The following is a description of a gene set: Transcriptome of human HepaRG hepatocellular carcinoma liver progenitors in responses to a WNT3A-enriched microenvironment and dissection of pathways dependent on _-catenin and/or blocked by the SFRP-like Wnt inhibitor FZD8_CRD. from publication Mebarki S, Désert R, Sulpice L, Sicard M, Desille M, Canal F, Dubois-Pot Schneider H, Bergeat D, Turlin B, Bellaud P, Lavergne E, Le Guével R, Corlu A, Perret C, Coulouarn C, Clément B, Musso O (PMID 27191501) species: Homo sapiens Methods: Liver progenitor cells were incubated in a WNT-enriched microenvironment for 72hrs (200 ng/ml mouse recombinant purified Wnt3A from R&D Systems). Gene pathways dependent on downstream _-catenin were studied by _-catenin knockdown with specific siRNA. Gene pathways blocked by extracellular SFRP-like Wnt inhibitors were studied by co-incubating cells with recombinant purified FZD8_CRD (300 ng/ml, from R&D Systems). Independent culture experiments performed in triplicate include untreated cells or cells incubated with scrambled siRNA or with _-catenin-specific siRNA or with FZD8_CRD, alone or in combination with Wnt3A. Human Gene Set: MEBARKI_HCC_PROGENITOR_WNT_UP, and this is the list of marker genes: ENO2, ARHGDIB, PTPN22, MRC2, LCP1, CCN1, LCE1A, BMF, PRICKLE2, ALDH3A1, BNC2, FLNA (filamin A), ST6GAL2, CDCP1, CARMN, PKP3, PANX2, LRRC15, NDRG4, WFDC3, CENPVL3, TCF7, RASSF9, SEPTIN11, TNFAIP6, SPARC, CLIC3, LYPD1, EXT1, RDH10, HMCN1, LINC01173, DIP2C-AS1, IL1R1, CXCL3, TEX15, NINJ2, NR2F1-AS1, NIFK-AS1, ENSG00000227496, GRAMD1A, ITGB4, ENDOD1, ADAM19, TCHH, SLC26A2, FHL2, NXN, FIBCD1, TYRP1, CCDST, LZTS1, FBN1, CORO1C, CLDN2, SRPX2, CYP1B1, THBS2, TCOF1, ZNF827, SLC7A5, STK32B, PRAG1, MMP2, LINC03033, KANK1, COL5A2, JAM2, NANOS1, PCSK5, CCDC3, GBP1, PAMR1, COL1A2 (collagen type I alpha 2 chain), FAP, DNM3, SPOCD1, CGB3, TMEM158, SERPINE1, LUM, PCDHB15, HAPLN1, ITGA5, FBLIM1, LEF1, ARHGEF3, KLHL4, ZNF474, ARL4C, TRIM55, MYADM, DLX5, GOLGA8G, CCDC80, MYH9, USF1, SEMA3C, DISC1, RBM24, CCNG2, DPYSL3, MYL2, RSPO3, LAYN, TPM4, IGFL1, PDLIM3, CFAP74, RGCC, COL3A1, SPOCK1, NAV1, CHPF2, TGFBI, ADAM12, RNF43, MMD, ODAPH, MILR1, MMP7, PRR5L, MEX3B, JAG2, CTHRC1, POTEF, KLF7, OLFML3, PI15, MAGED4B, ZNF608, IGFL3, SLC38A3, CARD11, FN1, TGFB2, CRACDL, GLIPR1, ACTN1, DCAF15, GCNT1, MDM1, DPT, IGF2BP3, POTEKP, P4HA2, VCAN, CSRP3, FRMD5, IGFBP5, PDLIM7, LFNG, MOXD1, BMP1, DACT1, F3 (NCBI Gene Id 99486), SLC12A8, PITX2, NKD2, PLAUR, PHLDB1, EPYC, IHH, EPHB2, SCG5, EVI2A, ALDH7A1, CPEB1, KRT17P1, MRTFA, PPP2R2C, ARID3A, KIF26B, GNG4, LHB, MDFI, DCBLD2, COL1A1, SH3GL3, PSTPIP2, POTEM, CCR1, RARG, SLC1A3, STXBP6, ACTR3-AS1, CSF1R, NOG, EYA2 (NCBI Gene Id 2139), SH3GL1P2, SDC3, DCN, TNRC18P2, LINC01705, CLSTN2, MMP13, PDGFRL, MANCR, GRK3, PRSS23, CSPG5, ENSG00000268460, CRISPLD2